Given this list of marker genes GATA3, CA2, ATP6V0A4, CLDN16, HNF1B, SLC4A1, here is a description of the gene set: Human Gene Set: HP_DISTAL_RENAL_TUBULAR_ACIDOSIS A type of renal tubular acidosis characterized by a failure of acid secretion by the alpha intercalated cells of the cortical collecting duct of the distal nephron. The urine cannot be acidified below a pH of 5.3, associated with acidemia and hypokalemia. Distal renal tubular acidosis species: Homo sapiens